Given this list of marker genes GJB6, SEMA3E, PSMC3IP, AXIN2 (NCBI Gene Id 8313), NR0B1, SOX3, ORC6, MDM2, HLA-DRA, HESX1, HR, LHX4, SPRY4, CYP17A1, CYB5A, GNRH1, LPAR6, FSHB, BMP15, PROP1, NUP107, GLI2, MRPS22, LSS, APOE, ZBTB20, SRA1, FEZF1, WT1, ZFPM2, NR5A1, MSH4 (NCBI Gene Id 4438), LHB, FOXA2, AXL (AXL receptor tyrosine kinase), KRT74, POU1F1, ITGB4, TP63, GATA4, PPP2R3C, CDSN, SPIDR, ANOS1, DUSP6, LIPH, FOXL2, PSMB8, SNRPE, EPS8L3, FAT4, AR, RPL21, WWOX, KCTD1, FGF17, POLR3H (NCBI Gene Id 91605), VAMP7 (vesicle associated membrane protein 7), ADAMTS3, SRY (sex determining region Y), CCDC141, BNC1, OTX2, TBX3, FSHR, MAP3K1, ESR1, GNRHR, SOX9, DSC3, APCDD1, COL17A1, WDR11, ZSWIM7, CCBE1, GJB2, DHX37, here is a description of the gene set: Abnormality of secondary sexual hair Abnormality of the growth of secondary sexual hair, which normally ensues during puberty. In males, secondary sexual hair usually comprises body hair, including underarm, abdominal, chest, and pubic hair. In females, secondary sexual hair usually comprises a lesser degree of body hair, most prominently underarm and pubic hair. species: Homo sapiens Human Gene Set: HP_ABNORMALITY_OF_SECONDARY_SEXUAL_HAIR